The following is a description of a gene set: Human Gene Set: GNF2_MSH6 species: Homo sapiens Neighborhood of MSH6 mutS homolog 6 (E. coli) in the GNF2 expression compendium Neighborhood of MSH6, and this is the list of marker genes: PPP1CC, MRPS27, CCT3, SNRPF, CCT4, MSH6, MAD2L1, PAICS, RAN, RFC4, ADSL, MCM3, GNL3, RANBP1, CCT2 (NCBI Gene Id 10576), MTHFD2, PRKDC, MSH2, H2AZ1, SNRPE, IARS1, TCP1, RFC3, ITGB3BP, CSE1L, MLH1, LRPPRC, MRPL42, GMPS, HNRNPA2B1 (NCBI Gene Id 3181), LIG1